Given this list of marker genes Ccl3, Vamp2 (NCBI Gene Id 22318), Stx4a, F2rl1, Cd300a, Ighe, Fcer1a, Ccr2, here is a description of the gene set: The change in morphology and behavior of a eosinophil resulting from exposure to a cytokine, chemokine, cellular ligand, or soluble factor. studied in species Mus musculus Mouse Gene Set: GOBP_EOSINOPHIL_ACTIVATION